Given this list of marker genes NUP133, COQ8B, CRB2, NUP93, TPRKB, NUP85, KIRREL1, NUP160, NUP205, SGPL1 (NCBI Gene Id 8879), TBC1D8B, EMP2, MAGI2, LAMA5 (NCBI Gene Id 3911), DAAM2, AVIL, COQ6, here is a description of the gene set: Human Gene Set: HP_STEROID_RESISTANT_NEPHROTIC_SYNDROME Steroid-resistant nephrotic syndrome A form of nephrotic syndrome that does not respond to treatment with steroid medication, defined as persistent proteinuria despite 60mg/m2 or 2mg/kg for 8 weeks, after insuring no infection or non-adherence to medication. studied in species Homo sapiens